The following is a description of a gene set: Pathway Definition from KEGG: IGH-MMSET -> H3 => CCND2 IGH-MMSET fusion to transcriptional activation. Pathway ID: N00125. Pathway type: Variant. Pathway class: nt06240 Transcription. species: Homo sapiens Human Gene Set: KEGG_MEDICUS_VARIANT_IGH_MMSET_FUSION_TO_TRANSCRIPTIONAL_ACTIVATION, and this is the list of marker genes: H3C12, H3C4, H3C8, H3C6, H3C11, H3C3, H3-5, H3-4, H3C7, H3C14, H3-3A, H3-3B, NSD2 (NCBI Gene Id 7468), H3C1, H3C10, H3C13, H3C15, H3C2, CCND2